Given this list of marker genes PLEKHA1, EIF2B5, TBX3, SRD5A2, FANCG, ARID5B, ZFP42, MMP14, LEP, CASP2, LHFPL2, VGF, RAC1, WT1, EIF2B2, TIPARP, FOXL2, CASP3, UBB, NPPC, NOTCH1, ZFY, CYP19A1, SLIT3, BAX, FSHB, TYRO3, PCYT1B, INSR, DACH2, GNRH1, ADAMTS1, ESR1, INHA, SMAD4, MMP2, BRCA2, DMC1, CCDC182, CHD7, SCAPER, VEGFA, FZD4, NR2F2, ADCYAP1R1 (ADCYAP receptor type I), RETN, UMODL1, EREG, CEBPB, NR5A1, GDF9, FOXC1, FOXO3, FANCE, NR5A2, CTNNA1, STAT5A, NUP107, FSHR, LHX9, INHBB, ZNF830, PTX3, NOS3, RBP4, NRIP1 (NCBI Gene Id 8204), TP63, SPO11, BCL2, SFRP1, HYAL3, AMHR2, NOTCH4, SIRT1, MERTK, ATM, FANCA, FST (follistatin), STRA6, KDR, LHCGR, GPR149, SGPL1, NPR2, AFP, SOD1, SRD5A1, INHBA, CGA, PGR (progesterone receptor), TAF4, ZFPM2, BMPR1B, TNFAIP6, IDH1, LFNG, LSM14B, ANG, ZP3, AXL, KITLG, GAS2, LHX1, MSH4, BCAS2, EIF2B4 (eukaryotic translation initiation factor 2B subunit delta), SLIT2, ROBO2, FGF10, BAK1, AMH, STAT5B (signal transducer and activator of transcription 5B), WNT5A, IMMP2L, WNT4, MMP19, LRP2, UBE3A, CSMD1, NUPR1, DMRTA1, DACH1, PTPRN, BCL2L1, PDGFRA, KIT, here is a description of the gene set: Human Gene Set: GOBP_FEMALE_SEX_DIFFERENTIATION species: Homo sapiens The establishment of the sex of a female organism by physical differentiation.